The following is a description of a gene set: Mouse Gene Set: GOBP_POSITIVE_REGULATION_OF_ENDOTHELIAL_CELL_DEVELOPMENT Any process that activates or increases the frequency, rate or extent of endothelial cell development. species: Mus musculus, and this is the list of marker genes: Akap11, Add1, S1pr2, F11r, Cdh5, Cldn5, Dicer1, Proc